The following is a description of a gene set: studied in species Homo sapiens In pyrimidine salvage reactions, nucleosides and free bases generated by DNA and RNA breakdown are converted back to nucleotide monophosphates, allowing them to re-enter the pathways of pyrimidine biosynthesis and interconversion. part of: Nucleotide salvage Reactome Pathway: Pyrimidine salvage, and this is the list of marker genes: UPP1, DCK, UCK1, TK1 (NCBI Gene Id 7083), UCK2, CDA, TK2, UPP2, TYMP, PUDP, UCKL1